The following is a description of a gene set: from publication Amit I, Garber M, Chevrier N, Leite AP, Donner Y, Eisenhaure T, Guttman M, Grenier JK, Li W, Zuk O, Schubert LA, Birditt B, Shay T, Goren A, Zhang X, Smith Z, Deering R, McDonald RC, Cabili M, Bernstein BE, Rinn JL, Meissner A, Root DE, Hacohen N, Regev A (PMID 19729616) mouse primary BMDCs were stimulated with tlr ligands and gene expression changes were profiled on Affymetrix arrays Genes up-regulated in comparison of dendritic cells (DC) stimulated with LPS (TLR4 agonist) at 4 h versus DC cells stimulated with CpG DNA (TLR9 agonist) at 4 h. Human Gene Set: GSE17721_LPS_VS_CPG_4H_BMDC_UP studied in species Homo sapiens, and this is the list of marker genes: PTGS2, PRRX2, IL1RAP, RUNX2, IRF1, PAPOLG, ASAH2, ANGPTL2, DHRS11, OR51E2, RAB38, JARID2, SP110, RBM25, C19orf12, STK39, KPNA3, ZFP36L2, DYRK1B, LETMD1, PMEPA1 (prostate transmembrane protein, androgen induced 1), CLCF1, TAS1R1, ATP6V1D, SEZ6, TUFT1, RAB9A, F3, KLRK1, GABRA2, PARP9, ARHGAP8, MDFIC, TMEM219, RAB25, PDK3, HBEGF, PSAT1, STXBP3, PARP12, SAV1, KCNMB1, BFAR, FAM8A1, C8orf33, PNPT1, RACGAP1, DUSP2, DOK1, PCSK7, GNL1, TLK2, CALCRL, PTCH1, YTHDF1, AASS, KATNA1, CHPF, CXCR5 (C-X-C motif chemokine receptor 5), PROS1, CEMIP2, ITGA8, NR3C1, ZNF644, TLR3, CYP27A1, AFF1, DYNC1I1, RBM7, BST2, TNKS1BP1, SEC24B, SBDS, AP1M1, LARP1, PLEKHA7, HTRA2, CCRL2, LHB, GTF2F1, GBP4, NR0B2, ARHGAP35, REL, ZNF281, C11orf68, MXD1, SNX2, PSME4, SLC9A8, SPRED1, CCL4, WAC, RSBN1, CPSF2, IL15, RBL1, ACADSB, RFFL, BHLHE40, APPBP2, APLP1, PAXBP1 (PAX3 and PAX7 binding protein 1), SMAD1, CPT1A (carnitine palmitoyltransferase 1A), ACADL, PLCL2, JPT1, GYPC, UBE2F, C1QTNF4, ISOC1, CPEB3, FNDC3A, PIM1, TNFSF9, GNA13, PTPN2, TMEM268, ACSL1, SMPD3, TRA2A, CAMLG, UPF3B, PLSCR1, SLC6A4, XK, UBE2D1 (NCBI Gene Id 9335), NECTIN4, GCNT2, ATP1B1, CRBN, NKD2, PPM1B, ETNK1, TMEM9, SAP30, SLPI, USP47, TAX1BP1, SMAD4, FTCD, MYD88 (MYD88 innate immune signal transduction adaptor), CTLA4, IMPDH1, CPNE3, APAF1, CEP112, GNG11, CACNG2, TOMM70, PSMB1, WASHC4, MACIR, PLEKHA5, TPM2, EGFR, COCH, OIT3 (oncoprotein induced transcript 3), HINFP, ITLN1, RAG1, PTPRA, ACOT11, CIDEB, CD8A, CLN3, PLA1A, LPAR1, DNAJA1, STARD8, NMU, ICAM1, TOR1AIP2, MXI1, PSIP1, PIGM, DHH, VOPP1, KLF4, PRIM2, LAPTM4B, RDH11, ZNF260, DUSP16, MISP, TJAP1, CEP152, HEBP2, APOBR, CA4, WSB1 (NCBI Gene Id 26118), SLC52A3, ALDH1B1, SEH1L, SGCB (NCBI Gene Id 6443), ZNF264, CCND2, AP4B1, HMGB2